Given this list of marker genes ZNF260, FOXF1, ZNF821, ZNF680, ZNF497, KCNIP3, POU5F1B, DUX4, MED12, SOX10, ZNF524, GATA1, HSF4, RFX3, MYF6, ZNF735, BORCS8-MEF2B, GLIS1, FOXP2, HEY1, DMRTC2, ZNF329, OLIG1, SATB1, H2AZ1, LEUTX, FOSL1, HEY2, ZNF865, ZFHX4, ZNF66, FOXP1, FOXD4L3, ZNF611, ZNF311, ASCL2, ZNF683 (NCBI Gene Id 257101), NKX6-3, ZFP28, BCL6B, NFIB, THAP1, ZNF283, ZIC4 (NCBI Gene Id 84107), RXRA, FOXD3, ZNF189, ZNF485, ZNF277, ZNF85, RAD23B, EMX1, ZNF776, HOXA10, MAFA, EGR2, UHRF1, GTF3C5 (NCBI Gene Id 95853), ZNF546, ONECUT1, GZF1, HAND1, DPRX, KDM6B, HOXC11, ZNF516, NACC2, ZNF623, HOXA4, FOXD4L5, KLF7, ZKSCAN8 (NCBI Gene Id 7745), PER1, FIGLA, OTX1 (orthodenticle homeobox 1), ZNF649, KLF8, TFCP2, FOXN2, LITAF, FOXL2, YY1, POU6F2, POU4F2, POU5F1 (NCBI Gene Id 7934), ZNF835, DLX3, ZNF761, MYBL2, CPHXL, ZNF296, ZNF547, HOXA9, MYBBP1A, ZNF564, SREBF2, SNAI3, ZNF610, CUX2, HDAC4, NHLH2, RFX8, ZBTB26, ZNF772, NKRF, RFX1, CC2D1B, ZNF534, FOXB1, TIPARP, HMGA1, TCF21, RBAK, GLI4, ZBTB20, GSX1, WT1 (NCBI Gene Id 7490), ZSCAN25, ZNF75CP, RORB, E2F4, SOX11, TP73, ZIK1, NFIC, SOX2, SOX13, BCL11A (NCBI Gene Id 55085), ZNF431, RXRB, MYC, GATA2, PROP1, E4F1, ZIM3, FOXE1 (forkhead box E1), HSF2, CDX4, BATF2, IRF7, PATZ1, BRF2, FOXD4L1, ZNF746, POU3F4, ELF3, ZNF506, ARGFX, NFKB2, CHD7, TLX1, AHR, ZNF71 (NCBI Gene Id 7622), TP53, HINFP, BACH2, ZNF519, E2F6, HOXB3, ZBTB38, MSC, RAX2, ZNF251, MXI1, FOXN4, CEBPB, HOXB1, ZSCAN4, TGIF1 (TGFB induced factor homeobox 1), RAD21, RUNX3, ZFY, ZNF239, HIVEP2, RUNX1, FOXK1, ZNF284, ZNF355P (NCBI Gene Id 441955), MNT, IRX1 (iroquois homeobox 1), ZNF146, MEIS1, ZNF160, SOX7, VENTX, ZNF395, FEZF2, ZNF528, ZNF418, PAX1, ZNF382, ISL1, ZNF423, ZNF648, MEF2B, TCF15, SP7, TBP, HOXA2, SP5, HOXD9, FOXO4, ZNF470, ATOH7, ZNF362, KLF11, TPRX2, ZNF837, GCM1, ZNF713, FOXN3, ZNF677, GLIS2, SP2, TFDP1, NFATC2, KLF9, ZSCAN5A, ZNF165, ZSCAN32, ZNF281, ZNF888, FOXJ2, TCF12, E2F2 (NCBI Gene Id 1870), SLC2A4RG, SRF (serum response factor), GATA5, ZNF780A (NCBI Gene Id 284323), STAT3, HES1, EGR3, NR2C1, POU6F1, FOXK2, RXRG, HOXB9, CREB1, NR2E1, TCFL5, NR1H3, ZNF624, ZNF74, ZNF8 (zinc finger protein 8), SOX5, ZNF92 (zinc finger protein 92), ZNF419, ETS2, NKX2-3, HBP1, SPIC, NKX2-6, SOX4, HIF1A (NCBI Gene Id 3091), RBBP4, BHLHE41, SOX1, EN2 (engrailed homeobox 2), FOXD1, PLAGL1, MKX, GLI1, CDX2, GLIS3, LHX2, TAL1, ZGPAT, SMAD9, SMAD2, ZBTB7C, ZSCAN18, BCL6, HES6, NR4A2, ZNF607, ZNF502, ZNF805, ZNF232, GLI2, BHLHE40, ZNF444, UTY, ISL2, JUNB, TBX5, H3-3A (NCBI Gene Id 3020), ZNF662, ETV4, ZNF701, RELA, ZNF501, ZNF784, ZBTB33, ZFP2, TFAP2A, INSM1, KLF2, RARB, PGR, ZNF736, ZNF740, ZBTB14, PHOX2B, ESRRG, TET1 (tet methylcytosine dioxygenase 1), ZNF90, PAX9, CALCOCO1, ZNF331, ZNF446, SOX18, RUNX2, ZNF737, ZNF514, FOXL1, BMAL1, ZNF569, ZSCAN5DP, PROX1, KLF5, MAFB, SNAPC4, HOXD1, TFAP2C, ZBTB43, FOXA1, ERG, GFI1B, IRF9, HOXB6, ZNF345, ZNF280A, NFE2, SOHLH2, HMGB2, TBX18, NKX1-1, PTF1A, INSM2, ELK1, MECOM, ATF7, FOXE3, ZNF18, PBX3, TCF4, ZNF860, NKX2-5, ZSCAN29, ZNF408, FOXS1, PRDM4, DNMT3A, SMAD5, SOX9, ZNF324B, TRIM24, ZNF184, SREBF1, ZSCAN16, FOXA2, ZNF699, ZBTB17, ZSCAN26, NFATC4, HDAC1, HOXC4, SUB1, NEUROD4, ZNF727, FOXO3, ZSCAN10, NEUROG3, HOXA6, ZNF723, ZNF300, ZFHX3, OTX2, ZNF587, ZNF571, ZSCAN30, ZNF613, WIZ, ARX, NRIP1, ZNF580, EOMES, GABPA, SKIL, ZNF320, GRHL2, ZNF492, ZNF366, BRF1, ZNF628, ZNF562, SOX15, FOSB, ELL3, HDGF (heparin binding growth factor), RFX6, KLF10, PPARA, DACH2, ZNF496, TARDBP, ATF2, MESP1, ZNF584, RFX7, NKX6-2, MYBL1, ZNF500 (NCBI Gene Id 26048), SNAPC3, ZNF595, ZFP42, IRF6 (interferon regulatory factor 6), SALL1, ZNF256, FOXO3B, FLI1, ETV1, ZFP82, SIX6, ZNF98 (NCBI Gene Id 94841), ZFAT, ATOH8, ZBTB37 (NCBI Gene Id 84614), ZNF280B, NLRC5, PAX6, ZBTB25, PPARD, CREB3L1, ZNF551, ZNF543, KLF1, TCF7L2, FOXD4L4, ZNF775 (zinc finger protein 775), NFE2L1, GMEB2 (glucocorticoid modulatory element binding protein 2), KLF15, TP63, ZNF621, ZNF354B, EN1, ZNF254, ZNF263, TCF7L1, ZFHX2, HOXC9, POU2F1, OVOL2, ZNF792, ZNF660, POU3F1, MTA1, ZBTB7B, SKI, CEBPE, SNAI2 (NCBI Gene Id 6591), DMRTA1 (NCBI Gene Id 64125), ZBED1, HNF4A, ZBTB7A, AGO1, ZNF568, DMRTC1B, ZNF664, ZNF93, ZNF876P, THAP11, ZNF454, ZNF257, ELF1 (E74 like ETS transcription factor 1), SCRT2, VAX1, HOXB2, IRX5, ZNF724, ZNF573, DHX36 (DEAH-box helicase 36), HESX1, ZNF626, SARS1, ZNF354A, ZNF777, CARF, MEF2C, NFATC3, RORA, NR1H4, IRX2, ELF4, MXD1, ZNF639, ZNF273, IRF4, HDX, ZNF486, ZNF217, ZNF143, ZNF668, ZNF430 (zinc finger protein 430), BATF, NR1H2, ZNF892, ZSCAN1, NEUROD2, NFYA, MYB, ZNF341, USF2, SRY, ZNF202, PAX5, MYOG, ZNF728, H3-3B, FOXD4, DMRTA2, ZNF417, LYL1, ZNF136, TBX4, ZSCAN5C, TFEB, ZNF181, ZKSCAN1, EHF, ZNF324, TBX6, DMRT3, ZNF730, ZNF581, STAT1, TBX19, ZNF722, ESR1, ZBTB9, PAX3, SMAD3, MSGN1, GCM2, ZBTB48, PRDM5, ESRRB, IRX4, TFEC, ZNF449, MGA, ZNF675, ZNF689, HOXD10, ZNF536, TFAP4 (transcription factor AP-4), CDX1, NEUROD1, ZNF317, NSD1, ZNF264, ZNF334, HOXD4 (NCBI Gene Id 50714), ZNF671, ZNF655, GMEB1, ELL, PITX3, FEZF1, ZBTB1, TEF, PAX2, MYF5, ZNF221, SMAD4, ZEB2, RUVBL2, NRL, ZNF732, FOS, FOXF2, ELL2, ZIC5, POU1F1, MYOD1, EPAS1, ELK3, NEUROD6 (neuronal differentiation 6), NEUROG1, GSC2, NR2F1, ZNF81, DMRT1, CHD2, ZNF211, ZNF141, FOXP4, SIRT1, UBP1, RORC (RAR related orphan receptor C), NPAS2, HSF1, CREB5, KLF6, NOTCH2, NR5A2, HOXA13, ZFP14, FOSL2, STAT5A, HOXB13, FOXO1, ZNF681, ZFX, NFATC1, ZNF121, PITX2 (paired like homeodomain 2), NOTCH4, NEUROG2, DLX4, NFE4, SP4, ATF6B, ZFP30 (ZFP30 zinc finger protein), HIVEP1, ESRRA, ZNF710 (zinc finger protein 710), FOXQ1, CXorf65, ZNF695, GTF2IRD1, LEF1, SCRT1, ZKSCAN3 (zinc finger with KRAB and SCAN domains 3), ZNF880, NOTO, ZNF586, MYNN, TEAD1, WBP2, CRY1, USF1 (NCBI Gene Id 7821), ZNF597, MED8, ZEB1, ZSCAN5B, PAX8, ZNF793, CEBPD, ZNF396, ZNF679, MITF, ATOH1, NANOG, HES3, ZFP92 (ZFP92 zinc finger protein), TOP1, BHLHE23, PRRX1, FOXB2, ZNF322, ZNF114, ZNF852, E2F8, TBX1, POU3F3, POU2F3, KLF12, ZNF692, FOXC2, SOX6, ATF1, HOXB5, ZNF287, ZNF530, PRDM15, DLX1, POU5F2, GFI1, NHLH1, ZNF383, ZBTB41 (NCBI Gene Id 360023), TBX2, ZSCAN22, SATB2, HOXC13, PAX7 (NCBI Gene Id 5081), EVX2, DACH1, HOXC6, NR2F6, ZBTB6, ZIC1, ZNF483, CLOCK, ZNF347, IKZF2, NR2C2, ZNF813, TFAP2B, MYT1L, TET3, POU4F1 (NCBI Gene Id 730659), IRF3, TFE3, MYPOP, ZNF212, SOX17, ZNF766, PDX1, NFIL3, ZNF131, ZNF565, NKX2-1, ZNF140, ZNF879, ZNF552, THRB, KLF17, ZBTB22, IRX6, ZNF676, FOXP3, OLIG3, RFX5, HOXD11, HAND2, BMAL2, ZIC3, HES5, CXXC1 (CXXC finger protein 1), FOXD2, ZNF302, ZNF829, MEOX2, ZBTB24, NFE2L2, ANHX, ZNF138, ZNF134, NR1D2, KLF14, ZNF790, EZH2, ZNF714, ZNF132, TEAD4, NFIA, NANOGP1, ESR2 (estrogen receptor 2), IKZF5, SKOR1, SPIB, ZNF479, ZNF16, ZNF350, STAT6, TBX20, ZNF570, NR2E3, ONECUT2, CEBPG, VAX2, KLF18, CREM, YY2, FOXH1, HMGA2, EBF3, ZNF83, ZNF682 (NCBI Gene Id 91120, zinc finger protein 682), CREB3L4, MAFK, HHEX, MAX, FEV, PRMT5 (protein arginine methyltransferase 5), MAFF, ZNF367, HOXB7, NKX2-2, NR1I3, REST, HNF4G, ZNF215, NR5A1, ZNF354C, NFKB1, NR2F2, ZNF548, POU2F2, ZNF540, DDIT3 (DNA damage inducible transcript 3), ZNF853, SOX8, EGR4, TBX22, NFYC, FOXO6, MZF1, ZNF750, HEYL, RARG, ZSCAN23, POU4F3, FOXI1, DMRTB1, TAL2 (NCBI Gene Id 6887), ZNF174 (NCBI Gene Id 7727), SKOR2, HOXA11, E2F7, PRDM11, CREB3L2 (cAMP responsive element binding protein 3 like 2), ZNF575, TCF3, MUC1, LRRFIP1, ZNF335, CREB3L3, ZNF275, ZNF280D, HOXA7, ZNF490, NR4A3, ZNF616, ZNF333, DMRTC1, HNF1B, HNF1A, THRAP3, ZKSCAN5, E2F1, PRDM1, HOXC10, KLF4, LHX3, ZNF280C, HNRNPU, ZNF250, SMAD1, STAT2, CREB3, E2F5, OLIG2, NOBOX (NCBI Gene Id 402714), IKZF4, ZSCAN12, MEF2A, MESP2, ZBTB4, BCL11B, SOX14, NFYB, ZNF578, FOXD4L6, ZNF816, RFX2, HES4, ZNF28, NKX6-1, ZNF678, ZSCAN21, ZNF468, RREB1, TBX21, ZNF23, ZNF17, SPI1 (Spi-1 proto-oncogene), IKZF3 (NCBI Gene Id 22806), ZNF410, POU3F2, ZNF76, PRDM16, DBP, REL, NFE2L3, ZNF286B, ZNF100, DLX6, PKNOX1, ZSCAN9, IRF1, ZNF773, SAFB, PLAG1, ETV2, LHX1 (NCBI Gene Id 3975), IRF5 (NCBI Gene Id 84729), DMTF1, ZNF467, CIART, FOXA3, ZNF286A, FOXI2, ZBTB2, HOXA1, ZNF7, ZNF397, ETS1, ZNF426, NANOGP8, CEBPA, MIXL1, HELT, TEAD3, ASCL1 (achaete-scute family bHLH transcription factor 1), RFX4, ZNF716, STAT5B, ZNF697, ZNF774, DDN, ZNF630, ZNF37A, GRHL3, GATA3, MSX1, ZNF30, OVOL3, MEOX1, SOX21, CTCF, GSC, MED1, MYCN, RBMX, SIX5, ZNF461, CDK9, ZNF527, SCX, TBX10, MEIS2, MAFG, ZNF667, ZNF789, SP6 (Sp6 transcription factor), TBXT, ZNF415, RARA, XBP1, STK16, ZNF704, ATF6, BACH1, ZNF471, ZNF236, HIC2, EVX1, NPAS4, ZNF34, SIX2, EMX2, ZKSCAN4, EGR1, IKZF1, CCAR1, ZNF219, EBF4, TFCP2L1 (NCBI Gene Id 29842), NKX3-1, NFAT5 (NCBI Gene Id 10725), HCFC1, NKX1-2, IRF2, GLI3, MYCL, ARNT, NKX2-4, NTN1, ZBTB12, MLX, ATF3, SP9, ZNF670, ZBTB49, HOXD3 (homeobox D3), MLXIP, JUN, NKX3-2, SIX3, EBF1 (EBF transcription factor 1), ZNF480, NR4A1, GATA4, ZNF358, KDM2B, JDP2, ZNF711, RBPJL, ZNF429, YAP1, ZBTB32 (zinc finger and BTB domain containing 32), ARNT2, ZNF572 (zinc finger protein 572), ZIC2, ZNF549, ZNF394, MTF1, ZBTB39, FOXJ1, ZNF135, ZNF304, JUND, ZBTB8A, IRF8, PROX2, ATF4, SOX12, NFKBIZ, ZNF148, MEF2D, TEAD2, RELB, NR1D1, GRHL1, SP3, MAZ, MTOR, NR3C1, BHLHE22, DLX5, STAT4, EBF2, ELK4, ZNF577, KDM6A, MAF1, CRX, HIVEP3, ZBTB45, ZNF117, OGG1, ZNF213, TFAP2E, NACC1, OVOL1, BSX, NCOA2, NRF1, PAX4, E2F3, ZSCAN20, JMJD8, KLF3, ZNF253, CPHXL2, ZSCAN31, ZNF416, TBX15, ZNF195, ZNF274, HDAC6, ZNF718, ZNF665, FOXC1, ZNF561, IRX3, ZFP1, ZKSCAN7, ZNF12, DHX9, SP1, ZNF765, NOTCH1, SMC3, KLF13 (NCBI Gene Id 51621), HOXC5 (homeobox C5), ZNF646, ZNF460, MXD4, ZNF154, ONECUT3, PBX1, HLF, BPTF, AR, KLF16, MAF, SP8, NR6A1, NR3C2, SIX1, BATF3 (basic leucine zipper ATF-like transcription factor 3), SOX30, PITX1, ZNF763, ZKSCAN2, HDAC5, ZBTB34, HIF3A, HES2, CTCFL, ZBTB16, SOX3, SUZ12, BHLHA15, FOXJ3, TWIST1, VDR, ZNF691, ST18, ZNF75D, ZBTB11, HOXB4 (homeobox B4), PPARG, EEF1D, NTN3, HOXD13, PASD1, GATA6, PRRX2, RAX, ETV6, DLX2, ZNF707, NR1I2, ZNF32, TCF7, THRA, ZNF182, ZNF567, SMYD3, NFIX, MSX2, TBX3, ZNF644, HOXA3, SIX4, RBPJ, MLXIPL, ZNF205, ZNF780B, FOXI3, HOXA5, SNAI1, MXD3, ZNF420, CC2D1A, NKX2-8 (NK2 homeobox 8), ZNF24, ZNF583 (NCBI Gene Id 147949), DMRT2, TBR1, ZNF883, HES7, here is a description of the gene set: studied in species Homo sapiens Binding to a specific upstream regulatory DNA sequence (transcription factor recognition sequence or binding site, located in cis relative to the transcription start site (i.e., on the same strand of DNA) of a gene transcribed by some RNA polymerase. Cis-regulatory sites are often referred to as a sequence motifs, enhancers, or silencers. Human Gene Set: GOMF_CIS_REGULATORY_REGION_SEQUENCE_SPECIFIC_DNA_BINDING